The following is a description of a gene set: Genes up-regulated in comparison of unstimulated peripheral blood mononuclear cells (PBMC) cultured for 0 h versus PBMC cultured for 3 h with YF17D vaccine. The immune responses generated by YF-17D by profiling genes in PBMCs from 2 donors cultured with YF-17D vaccine were accessed after 3 and 12 hours. from publication Querec TD, Akondy RS, Lee EK, Cao W, Nakaya HI, Teuwen D, Pirani A, Gernert K, Deng J, Marzolf B, Kennedy K, Wu H, Bennouna S, Oluoch H, Miller J, Vencio RZ, Mulligan M, Aderem A, Ahmed R, Pulendran B (PMID 19029902) Human Gene Set: GSE13484_UNSTIM_VS_3H_YF17D_VACCINE_STIM_PBMC_UP studied in species Homo sapiens, and this is the list of marker genes: PCSK5, DOP1B, METTL3, SPEN (spen family transcriptional repressor), SNRPD3, EOLA2-DT (NCBI Gene Id 100272228), ECHS1 (NCBI Gene Id 1892, enoyl-CoA hydratase, short chain 1), MAN2B1, BMPR1A, AKAP7, SIN3B, TBC1D2, TCF20, PAPOLG, RSAD1, ATG4A, FAM136A, SPTLC1, MRPS28, AMELY (amelogenin Y-linked), GPI, C2CD3, METTL13, CEP68, ZBTB16, NFE2, DENND1C, CX3CR1, SDHAF1, DCUN1D4, RETREG2, DLG1, ATPAF2, ITGAE, FCMR, RXRA, THOC7, TBC1D22A, PIP4K2C, NDE1 (NCBI Gene Id 95348), SSR1, MMP15, SUN1, XPOT, UROS, NPRL2, RFC4, RCN1, DDX51, SPAST, PCSK7, STMN3, TCF3, THADA, SGSM2, MATR3, STXBP2, NBEAL2, RMND1, DDX39B, DSTYK, PFDN5, EPHA1, FAM117A, PMM1, AP3D1, SEC11A, TBX5 (NCBI Gene Id 6910), CNOT9, LRBA, ACOT8, NUDCD3, PTCD3, TEX2, TBC1D9, AGO1, PSTPIP1, CAPN10, IDH3G, INO80B, DOCK9, TPD52, CDK13, LILRA1, NAGLU, SPOP, HTRA2, NCK1, ARHGEF18, PTTG1IP, COG4, PRDX3, AXIN1, CBX3 (NCBI Gene Id 82756), LDHB, ZMYM3, COLQ, ACSM3, PPP6R1, ACADM, ANKRD36B, ANK1, CALML4, POPDC3, MEGF9, CASP8AP2, TCFL5, COQ8A, ANAPC5, AKAP1, PFKM, ZNF106 (zinc finger protein 106), DDX42, ERBIN, GPSM3, SIRT6, SKAP2, LRRC61, CD40LG, AP1AR, HEATR6, ZZEF1, UBE4A, DNAJB14, ZFAND3, CNOT3, ARHGEF6, XYLT2, NCK2 (NCK adaptor protein 2), TCF12, P2RX5, EFHD2, TRAC, UBAP2L, DDX49, MYG1, CYTH4, FBXO41, TTBK2, OPRPN, SEPHS2, GBA1LP, SNX29, PPP2R5E, DAG1, RBM4B, CHFR, BSCL2, ENOPH1, DIAPH1, CENPT, NELFCD, SPTBN1, SLC25A36, DPEP2, CEP350, SIDT2, ADH5, AMZ2, WASF2, CAST, PCYOX1L, CAPRIN2, RPS6KA5, CD27, SLC2A4RG, NOMO3, DPP8, PPP1CC, NAA40, ZNF177, ABCC5, SHC1, TMEM14A, APPL2, MRE11, RCBTB2, ATP5IF1 (ATP synthase inhibitory factor subunit 1), TNFSF13, MRPL3, KMT2D, PDSS2, USP20, SEC31B, CABIN1, EPHX2, SMARCC2 (SWI/SNF related, matrix associated, actin dependent regulator of chromatin subfamily c member 2), LIMK1, UBE3B, CYBC1, SLC39A1, DDX23, TCEAL1, MAN2A2, TUBA1A, CEP135, CPSF6, MSRB2, FBXL5